Given this list of marker genes CDK7, HDAC3, CDK1, RBP1, VDR, MAPK14, NRIP1, NCOA1, RXRB, AKT1, CCNH, MAPK3, PRKCG, NCOA3, EP300, PRKCA, RARA, MNAT1, KAT2B, CREBBP, RARG, PRKACA, NCOA2, HDAC1, MAPK1, RXRA, MAPK8, NCOR2, RARB, RXRG, here is a description of the gene set: studied in species Homo sapiens Retinoic acid receptors-mediated signaling Human Gene Set: PID_RETINOIC_ACID_PATHWAY from publication Schaefer CF, Anthony K, Krupa S, Buchoff J, Day M, Hannay T, Buetow KH (PMID 18832364)